Given this list of marker genes HSP90AA1, ERBIN, CDC37 (cell division cycle 37, HSP90 cochaperone), ERBB2 (NCBI Gene Id 2064), here is a description of the gene set: part of: Drug resistance in ERBB2 KD mutants This pathway describes resistance of ERBB2 KD mutants to tyrosine kinase inhibitor afatinib. Reactome Pathway: Resistance of ERBB2 KD mutants to afatinib species: Homo sapiens